Given this list of marker genes VDAC3, APP, PLCB3, GRM5, GNAQ, VDAC2, MCU, PLCB2, SLC25A6, CASP3, SLC25A4, ITPR1, APAF1, ITPR2, CYCS, VDAC1, PLCB1, SLC25A31, PLCB4, SLC25A5, ITPR3, CASP9, here is a description of the gene set: species: Homo sapiens Mutation-caused aberrant Abeta to mGluR5-Ca2+ -apoptotic pathway. Pathway ID: N01002. Pathway type: Variant. Pathway class: nt06460 Alzheimer disease. Pathway Definition from KEGG: APP* -> Abeta -> GRM5 -> GNAQ -> PLCB -> IP3 -> ITPR -> Ca2+ -- MCU -> Ca2+(mito) -- MPTP -> CYCS == APAF1 -> CASP9 -> CASP3 Human Gene Set: KEGG_MEDICUS_VARIANT_MUTATION_CAUSED_ABERRANT_ABETA_TO_MGLUR5_CA2_APOPTOTIC_PATHWAY